Given this list of marker genes IL6ST, IL12RB2, STAT1, STAT4, EBI3, JAK1, JAK2, STAT3, TYK2, IL12A, CANX, IL27RA, here is a description of the gene set: studied in species Homo sapiens Reactome Pathway: Interleukin-35 Signalling Interleukin 35 (IL35) is an IL12 family cytokine produced by regulatory but not effector T-cells. It is a dimeric protein composed of IL-12RB2 and IL27RA chains. IL35 suppresses inflammatory responses of immune cells. part of: Interleukin-12 family signaling